Given this list of marker genes Foxj1, Bcr (BCR activator of RhoGEF and GTPase), Tax1bp3, Rapgef1, Nedd9, Apc2, Tiam1, Arhgap24, Coro1c, Ect2 (NCBI Gene Id 99670), Dock7, Rhog, Sipa1l1, Ntrk3, Arhgef16, Rasgrp1, Wnt5a, Tsc1, Akt2, Pip5k1a, Arhgef10, Cxcl13, Ccdc125, Rasgrf1, Arhgap42, Epha1, Rangap1, Rcc2, Ndel1, Gpr65, Scrib, Crkl, Slc27a4, Ralgapb, Ntf3, Ptk2b, Abr, Ralgapa2, Tbc1d7, Mtss2, Crk, Ralgapa1, Epha2, Syde1, here is a description of the gene set: Any process that initiates the activity of an inactive GTPase through the replacement of GDP by GTP. Mouse Gene Set: GOBP_ACTIVATION_OF_GTPASE_ACTIVITY studied in species Mus musculus